Given this list of marker genes ARID5B, PLEKHA1, ZNF880, SCHIP1, ZFAND5, SGPL1, MYO1E, TXNIP, TIPARP, CSRNP1, here is a description of the gene set: Human Gene Set: SCHMAHL_PDGF_SIGNALING Growth factor signaling leads to the induction or repression of immediate early genes, but how these genes act collectively as effectors of downstream processes remains unresolved. We have used gene trap-coupled microarray analysis to identify and mutate multiple platelet-derived growth factor (PDGF) intermediate early genes in mice. Mutations in these genes lead to a high frequency of phenotypes that affect the same cell types and processes as those controlled by the PDGF pathway. We conclude that these genes form a network that controls specific processes downstream of PDGF signaling. from publication Schmahl J, Raymond CS, Soriano P (PMID 17143286) studied in species Mus musculus These genes form a a network that controls specific processes downstream of PDGF signaling.